The following is a description of a gene set: Human Gene Set: GOBP_UDP_BIOSYNTHETIC_PROCESS The chemical reactions and pathways resulting in the formation of UDP, uridine (5'-)diphosphate. species: Homo sapiens, and this is the list of marker genes: DHODH, CMPK1, AK9, CAD, UMPS